Given this list of marker genes XPO6, NEDD4L, ANGEL1, ZSCAN20, CRTAM, SLC35D2, TNIK, FAM78A, PACS2, GIMAP5, IL4R, ITGB7, FOXK1, SMC6, TDRP, DIPK1A, TRIB2, NUMB, VSIR, RAB11FIP2, RLIG1, RASGRF2, PTPRA, SMAD5, LDLR, CACNA2D2, KCNE4, ZNF526, C8orf58, OSBPL9, PCGF1 (NCBI Gene Id 84759), LRRC24, SLC16A5, CFLAR, SQLE, PDCD4, RASGRP1, CDC14B, SUSD6 (NCBI Gene Id 9766), PPM1H, EMB, FLI1, LYPD6B (NCBI Gene Id 130576), EMC2, MFHAS1, SGK1, BCL11B, EFS, N4BP2L1, NCK1, TNRC6B, FBXO17, TGM4, WDR20, BMP2K, NOD1, THEMIS, MYO10, GPBP1, LETM2, DEDD2, NSUN6, RFLNB, SMC4, TRMO (tRNA methyltransferase O), CCDC22 (NCBI Gene Id 28952), LFNG, PACS1, PDE4DIP, HERC3, ACAP2, CNST, FOXJ2, PCED1B, WASHC3, TMED8, SELENOP, ADRB2, SARAF, RAB33B, OTULINL, ENPP4, ZNF280B, GPR146, ZNF563, TIPARP, CALCRL, SEC22C, HERC4, ESYT2, CARD6, ADGRE5, GPR174, TBC1D14, SPICE1, TXNIP, ANKRD44, KCNN4, FMO5, ZNF655, QPRT, TNFRSF25, MPP1, ENTREP3, PHYHD1, IDS, CELF1, JCHAIN, NACC2, THADA, ERC2, IGKC, RSBN1, GPR180, GPC1, FHIP1B, PPM1K, CDIPT, MITF (melanocyte inducing transcription factor), IBTK, ACSS1, CCM2, USP24, GALR1, TMEM141, MBP, RTN4RL1, IFT80, PEX26, IMPDH1, MS4A6A, ARHGAP29, SPACA1, SQOR, RGS6, EDEM1, TERF1, C16orf54, LRRC23, ZFAND6, SGMS1, TSC22D3, APLP2, OSM, JADE2, ZNF383, SLC30A7, TBXA2R (NCBI Gene Id 6915), GFOD2, TGFBR3, TRAF3IP2, HID1, CRLF3, RGS14, ACOXL, MAF1, CASP8, BACH2, PDE5A, ATP11C, THY1, KBTBD8, EXD1, HIPK1, IL6ST, ETFBKMT, MAN1A1, ALDH6A1, SLC30A1, KYAT1, BBS9, CCNB1IP1, PCSK9, ZBTB6, NCK2, CNN2, DHX40, C2orf68, PRF1, RASA3 (RAS p21 protein activator 3), CYTH3, PAQR7, ADD1, TMEM71, HSD11B1, BBX, TMEM63A (NCBI Gene Id 9725), STK38, INPP5F, CYP2S1, MARCHF7, STIM2, TRAT1, DAAM1, ZBTB2, PANK3, NIN, ACTN1, RAB3IP, SETD4, here is a description of the gene set: species: Homo sapiens Genes up-regulated in CD8 T cells treated by inteferon alpha: wildtype versus STAT4 knockout. Human Gene Set: GSE40666_WT_VS_STAT4_KO_CD8_TCELL_WITH_IFNA_STIM_90MIN_UP from publication Gil MP, Ploquin MJ, Watford WT, Lee SH, Kim K, Wang X, Kanno Y, O'Shea JJ, Biron CA (PMID 22968462) Type 1 IFNs can conditionally activate all of the signal transducers and activators of transcription molecules (STATs), including STAT4. The best-characterized signaling pathways use STAT1, however, and type 1 IFN inhibition of cell proliferation is STAT1 dependent. We report that type 1 IFNs can basally stimulate STAT1- and STAT4- dependent effects in CD8 T cells, but that CD8 T cells responding to infections of mice with lymphocytic choriomenigitis virus have elevated STAT4 and lower STAT1 expression with significant consequences for modifying the effects of type 1 IFN exposure. The phenotype was associated with preferential type 1 IFN activation of STAT4 as compared to STAT1. Stimulation through the TCR induced elevated STAT4 expression, and STAT4 was required for peak expansion of antigen-specific CD8 T cells, low STAT1 levels, and resistance to type 1 IFN-mediated inhibition of proliferation. Thus, a mechanism is discovered for regulating the consequences of type 1 IFN exposure in CD8 T cells, with STAT4 acting as a key molecule in driving optimal antigen-specific responses and overcoming STAT1-dependent inhibition of proliferation.